Given this list of marker genes SLC15A2, PDZK1, RALBP1, MIR873, MIR186, MIR133A1 (NCBI Gene Id 406922), MIR495, ABCA3, ATP7B, MIR133B, SLC47A1, OSCP1, MIR508, ABCB1, ABCG1, ABCB11, MIR185, MIR326, SLC22A18, SLC17A3, MIR129-1, MIR451A, MIR34B, MIR9-1, ABCC5, ABCC2, SLC47A2, MIR1-1, SLC22A5, here is a description of the gene set: studied in species Homo sapiens Human Gene Set: GOBP_XENOBIOTIC_EXPORT_FROM_CELL The directed movement of a xenobiotic from a cell, into the extracellular region. A xenobiotic is a compound foreign to the organism exposed to it. It may be synthesized by another organism (like ampicilin) or it can be a synthetic chemical.